Given this list of marker genes Pakap, Chchd3, Kat6a, Kirrel1, Bub3, Ptgfrn, Aak1, Pcdhac2, Sec11c, Smad6, Rps6ka5, Mesp2, Pnrc2, Tnrc6c, Slc38a9, Pcdha7, Bhlhe40, Dio2, Vps33a, Vps4a, Wnt7a, Cyp2ab1 (NCBI Gene Id 224044), Igsf1, Cdon, Fam120a, Gad1, Twist1, Dennd2a (NCBI Gene Id 209773), Bnc2, Gm14434, Lbh, Slc24a2, Adam10, Sh3kbp1, Ormdl1, Phactr2, Fxr2, Grm4, Cpeb2, Wbp2, Rbfox2, Fry, Usp49 (ubiquitin specific peptidase 49), Hmx2, Camsap3 (calmodulin regulated spectrin-associated protein family, member 3), Adam22, Kdm7a, Amotl1, Erlec1, Ash1l, Ipcef1, Cnr1, Rora, Sowaha, Slc17a2, Gm14308, Smpd1, Iqub, Lypd6, Zfp1005, Nrxn1, Rab11fip2, 2210418O10Rik, Cpox, Zfp704, Rad54b, Pcdha4, Papss2, Gria3 (glutamate receptor, ionotropic, AMPA3 (alpha 3)), Zbtb41, Acox1, Plppr1, Spred1, Epha7, Ccser2, Zfp931, Arv1, Pcdha10, Arhgef12, Rhoa, Rab3a, Il6st, Foxn2, Mgat4c (NCBI Gene Id 67569), Gucy1a2, Nufip1, 2810408A11Rik, Pcdha2, Rspo1, Klhl18, Slc1a7, Purb (NCBI Gene Id 76437), Pcdhac1, Ttll7, Tut4, Cldnd1, Shisa9, St3gal5, Cdk12, Pik3r1, Synm, Nfia, Abhd13, Mtmr1, Pcare, Nemp1, Zfp710, Pcdh20, Gm4724, Rpf2, Ms4a4b, Pcdha5, Abcd2, Csnk1e (casein kinase 1, epsilon), Ppp4r3a, Postn, Sp3, Pcdha6, Dip2c, Setx, Gm14325, Tnks2, Zfp354b, Cpsf6, Glce, Cpne2, Msl1, Pyroxd1, Ccdc65, Agpat1, Inpp4a, Bcl11a, Gigyf2, Nav2, Arid3a, Saxo2, Hnf4g, Tmem248, Magi1, Raph1, Trim45, Pphln1, Papolg, Dlg2, Gpr149, Hoxd8, St8sia4, Raly, 1110004F10Rik, Csrnp3, Tmem35a, Gpd2, Klhl11, Uros, Zfp971, Klhdc10, Ablim1, Plppr4, Wnt3, Tmem165, Sparc, Zfp101, Jrkl, Map3k2, Lrguk (leucine-rich repeats and guanylate kinase domain containing), Ppm1d, Pappa2, Hand1, Spty2d1, Rpn2, Amd2, Fut9, Enc1, Amhr2, Olig3, Hyal6 (NCBI Gene Id 74409), Lrba, Galnt2, Gins3, Gnao1, Fignl1, Cd9, Cx3cr1, Cyp20a1, Btbd1, Mgat3, Scmh1, Oard1, Mef2a, Nqo2, Tnrc6b (NCBI Gene Id 72625), Spam1, Tbc1d8b, Tmem30c, Eif5, Tfdp1, Npr3, Gtf2ird2, Tgfbr3, Galnt13, Gm2026, F5, Sephs2, Pak1 (p21 (RAC1) activated kinase 1), Mmp16, Mark2, Dclk1, Cacna1g (calcium channel, voltage-dependent, T type, alpha 1G subunit), Igfbp5, Trabd2b, Erbb4, Map3k7, Etv6, Pag1 (phosphoprotein associated with glycosphingolipid microdomains 1), Rbm20, Iqgap2, Sema6d, Tnfsf12, 4930544G11Rik, Scai, Npc1l1, Supt5, Utrn, Scml2, Hycc2, Mex3c, Trpm1, Pdcd6ip, Foxp1, Gm14391, Gabra1, Rps6kb1, Atad2b, Synj2bp, Lrrc58, Caps2, Ptger4, Zfp362, Psg16, Cpeb3, Cd200, Pcdha12, Grpel2, Ttc23 (NCBI Gene Id 67009), Tspan2, Iqsec3, Trio, Chic1, Zscan29, Patl1, Rorb, Ypel2, Leng8 (NCBI Gene Id 232798), Rgl1, Sh3glb1, Myot, Pus10, Vegfa, Plp1, Ubxn4, Msi2, Crispld1, Atp5f1a, Acsm2, Ctdsp1, Itpk1, Mafg, Npas2, Hhip, Emb, Pcdha9, Spata31f1a, Stradb, Cd2ap, Mroh9, Pip5k1b, Zfp1004, Pcdha3, Cnot9, Asgr2, Slain2, Slc25a16, Svs4, Pcdha11, Zfp503, Chrdl1, Mfsd4b5, Fez2, Ppp1r9a, Scoc (NCBI Gene Id 80484), Cask, Gatc, Smim10l1, Pter, Jtb, Pcdh15, Pcdha1, Pip4p2, Zeb2, Mtrfr, Atxn3, Spp1, Chdh, Ube2j2, Setd3, Gabrb2, Vwc2l, Gtf3c4, Ankfy1, Gnb1, Kdm4b, Rsf1, Acer3, Rab30, Il23a, Lpgat1, Fam199x, Pdzd2 (NCBI Gene Id 75144), Rc3h2, Desi1, Nckap5, Zfp263, Nptx2, Vdac3 (NCBI Gene Id 22335), Tmem260, Gpr158, Gypa, Gm14296, Ptpre, Trim8, Ddhd1, Bloc1s6, Lrrtm4, Mex3b, Gorasp2, Lpp, Htr7, Ube4b, Gm6710, Satb1, Unc5d, Stx11, Tmem47, Mlec, Slk, Ddost, Rsbn1, Hivep2 (NCBI Gene Id 15273), Vipr2, Ctdspl2, Haspin (NCBI Gene Id 14841), Rab3b, Bola1, Fgf12, Sgms1, Fgf10, Fbxo11, Trim52, Cldn19, Acot8, Bdh1, Camk1d, Ms4a4c, Ppp2cb, Hmgcs2, Grm5, Rnf152, Caskin1, Crppa, Lsm8, Ago2, Adam6a, Plpp3, Sptssb, Arf1, Eif4e3, Mbnl3, Spata19, Glyctk, Nova1, Cnot1, Fgfr3, Spata31f1b, Ints2, here is a description of the gene set: from publication Chen Y, Wang X (PMID 31504780) Genes predicted to be targets of miRBase v22 microRNA mmu_miR_692 in miRDB v6.0 with MirTarget v4 prediction scores > 80 (high confidence targets). Mouse Gene Set: MIR_692 species: Mus musculus